The following is a description of a gene set: Any process that modulates the frequency, rate or extent of excitatory postsynaptic potential (EPSP). EPSP is a process that leads to a temporary increase in postsynaptic potential due to the flow of positively charged ions into the postsynaptic cell. The flow of ions that causes an EPSP is an excitatory postsynaptic current (EPSC) and makes it easier for the neuron to fire an action potential. species: Homo sapiens Human Gene Set: GOBP_MODULATION_OF_EXCITATORY_POSTSYNAPTIC_POTENTIAL, and this is the list of marker genes: RIMS2, PRKAR1B, GRIK2, EIF4A3, TMEM108, NETO1, MTMR2, CHRNA7, NRXN1, TMEM25, NLGN3, PRKN (parkin RBR E3 ubiquitin protein ligase), SLC8A3, NLGN2, GRIN1, RGS4, BAIAP2, STX1B, SHANK1, GRIA1, GRIN2B, MAPK8IP2, MIR30B, PTK2B (NCBI Gene Id 5748), GRIN2A, GRIN2D, SSH1, PRKCZ, SHANK3, LRRK2, S1PR2, CBLN1, DVL1, RIMS1, PTEN, NPY2R, WNT7A, APP (amyloid beta precursor protein), DLG4, STX1A, TBC1D24, SLC8A2, DMPK, ADRB2, RELN, NLGN1, CUX2, GRIN2C, NLGN4X, CELF4 (CUGBP Elav-like family member 4), ZMYND8